The following is a description of a gene set: Binding to the microtubule constituent protein beta-tubulin. Mouse Gene Set: GOMF_BETA_TUBULIN_BINDING studied in species Mus musculus, and this is the list of marker genes: B4galt1, Map1s, Eml4, Pex14, Rgs2, Slc6a2, Pdcd5-ps, Trpv4, Hdac6, Uxt, Htt, Adnp, Bbs4, Lrpprc, Ranbp10, Bcas3, Akap1, Dnai7, Vapb, Fgf13, Spast, Snca, Tbcd, Cct5, Tbca, Syt11, Appl1, Gjb6, Pacrg, Emd, Pdcd5, Ttll7 (tubulin tyrosine ligase-like family, member 7), Taok1, Sncb, Racgap1, Gja1, Ift74, Arl8b, Smc3, Ndel1, Dlec1, Clxn, Cimap3, Sncg, Gabarap